Given this list of marker genes ORMDL1, ORMDL3, SPTLC1, SPTSSB (NCBI Gene Id 165679), SPTSSA, ORMDL2, SPTLC3, SPTLC2, here is a description of the gene set: species: Homo sapiens A protein complex that catalyses the condensation of L-serine with palmitoyl-CoA to form 3-ketosphinganine, the sphingoid base which is the starting point for all sphingolipids. In bacteria the enzyme is a cytoplasmic homodimer, whereas in eukaryotes the enzyme is a multiprotein complex localised to the endoplasmic reticulum. The eukaryotic complex consists of catalytic components (SPTLC1, SPTLC2 and SPTLC3 in humans; LCB1 and LCB2 in S. cerevisiae) and regulatory components, which include activators (SPTSSA/SPTSSB in humans, TSC3 in S. cerevisiae) and negative regulators (ORMDL1/ORMDL2/ORMDL3 in humans, ORM1/2 in S. cerevisiae ). Human Gene Set: GOCC_SERINE_PALMITOYLTRANSFERASE_COMPLEX